Given this list of marker genes ZNF445, SGF29, H2AC20, DOT1L, SUV39H2, TASOR2, RLF, H1-0, TDRD12, SMARCA5, SMARCD1, H2AC13, APEX1, HDAC3, EED, PIWIL2, ZFP92, RESF1, DNMT1, ALKBH4, ASH2L, HMGB1, WBP2, EZH2, TDG, TUT4, PPM1D, APOBEC3C, ARB2BP, H2AC12, HDAC2, CBX1, SPEN, H2AB2, HNRNPU, MOV10, H2AJ, MYOCD, ZNF93, PIWIL1, SIRT6, LHX2, N6AMT1, ATAD2, MBD3L5, LMNB1, HAT1, ARID1A, MSL2, CDKN2B-AS1, PHF8, KDM1B, KMT2D, SAMD1, H3C8, HDAC11, TET3, PTENP1-AS, CBX3, CDYL, SDR16C5, HDAC5, ZNFX1, RLIM, DYRK1A, ATF7IP, GSK3A, TUT7, BRCA1, ZMPSTE24, XIST, USP21, H2AC4, HDAC7, ZNF304, H2AX, DIRAS3, APOBEC1, PCID2, HDAC9, PIK3CA, TET2, KPNA7, DNMT3L, RB1, GLMN, NRDE2, APP, RIF1, ASIP, EHMT2, KAT8, MBD3L2, PHF2, MACROH2A1, DPPA3 (NCBI Gene Id 359787), UBR2 (NCBI Gene Id 255838), JARID2, MACROH2A2, CGGBP1, H2AC6, MIS18A, H2AC19, KMT2E (NCBI Gene Id 84147), BMI1, MTA2 (metastasis associated 1 family member 2), H3C3, FAM47E, TRIM37, EGR1, H1-2, H2AC16, H2AZ1 (H2A.Z variant histone 1), UHRF2, SIRT2, H3-3A, NOC2L, SIN3A, SETDB1, VPS72, APOBEC3A, HELLS, GLYR1, TASOR, UBR5, H1-8, PARTICL, ZNHIT1, ASZ1, PHF19, EZH1, HIPK2, SMARCA4, ZFP57, TET1, TRMT112, H2AZ2, GPX1, SMARCB1, MTA1, RRP8, MIR29C, H3C7, H3C12, USP7, MYCN, STPG4, METTL4, CTCFL, ARID1B, TRIM28, H1-9P, H3C2, HMGA2, PHB1, SMARCAD1, SMYD5, SUV39H1 (SUV39H1 histone lysine methyltransferase), NDN, WDR5, CTCF, TNP1, DNMT3A, H2AB3 (H2A.B variant histone 3), MBD3L4, HDAC6, AICDA, PCGF5 (polycomb group ring finger 5), METTL23, SPHK2, EPC1 (enhancer of polycomb homolog 1), H2AC11, SPOCD1, KDM5A, KLF2, MIR29A, CDK2, LMNB2, DCAF13, YTHDC1, MORC2, BTBD18, CBX5 (NCBI Gene Id 23468), ARB2A, TRIM27, H2AC15, MBD3L3, ARID4A, MEN1 (menin 1), OGG1, ING2, MAEL, SUZ12, ZDBF2 (NCBI Gene Id 57683), SCMH1, PCGF3, KAT2B, TPR, TFAP2C, MOV10L1, DDB1, TP53, MPHOSPH8, H3-3B, LBR, BAZ1A, BAP1, RBBP5, IFI16, PADI2, HDAC10, RNF8, H2AC17, SIRT7, H2AP, SMARCA2, BAHD1, PHF1, PIWIL4, BCL6, EZHIP, MTF2, CENPV, DPY30, HDAC4, CREBZF, EP300, TDRD1, L3MBTL1, APOBEC3G, TEX15, APOBEC3B, H2AC1, MBD3, PADI6, H2AC18, MBD2, H2AB1, DDX4, SPTY2D1, KAT7, ALKBH1, APOBEC3F, MBD3L1, H3C1, IGF2 (insulin like growth factor 2), C19orf84, RBM15, LMNA, TRIP12, MBD1, RBM15B, AXIN1, FKBP6, SAMD7, PRDM14, ARID4B, PRMT7, BAZ2A, MIR182, H3C11, H2AL3, H3C6, TDRD9, TDRD5, HDAC8, METTL3, H2AC7, LRIF1, H2AC25, MORC1, SMARCA1, H3C10, TLE6, PRMT5, SPI1, CDKN1C, ATRX, ZNF335, RNF168, ATF2, MYC, BEND3, PRMT3, H2AC8, L3MBTL3, KDM1A, MIR29B1, KMT2A, PPHLN1, HDAC1, UHRF1 (NCBI Gene Id 96185), MBD3L2B, MECP2, CTR9, BRD7, HNRNPK, EHMT1, ZNF91, SMCHD1, H3C4 (NCBI Gene Id 8351), H2AC21, WT1, ATAD2B, SPIN1 (NCBI Gene Id 95616), POLE3 (DNA polymerase epsilon 3, accessory subunit), APOBEC3H, APOBEC2, CIZ1, RBM14, CHEK1, RNF2, TEX19, SIRT1, here is a description of the gene set: Human Gene Set: GOBP_EPIGENETIC_REGULATION_OF_GENE_EXPRESSION studied in species Homo sapiens A process that modulates the frequency, rate or extent of gene expression through chromatin remodeling either by modifying higher order chromatin fiber structure, nucleosomal histones, or cytosine methylation of DNA. Once established, this regulation may be maintained over many cell divisions. It can also be heritable in the absence of the instigating signal.